Given this list of marker genes SHOX, EXT1, MSX2, TRPS1, RAD21, PTPN11, EXT2, ALX4, here is a description of the gene set: Human Gene Set: HP_MULTIPLE_EXOSTOSES Multiple exostoses studied in species Homo sapiens Presence of more than one exostosis. An exostosis is a benign growth the projects outward from the bone surface. It is capped by cartilage, and arises from a bone that develops from cartilage.